Given this list of marker genes Casq1, Actn3, Agt, Prkag3, Trim63, Fbxo32, Dag1, Sgca, Selenon, Srl, Rps6kb1, Mtmr4, Ndufs4, Hdac4, Scn5a, Myog, Nol3 (nucleolar protein 3 (apoptosis repressor with CARD domain)), Dmd, here is a description of the gene set: Mouse Gene Set: GOBP_RESPONSE_TO_STIMULUS_INVOLVED_IN_REGULATION_OF_MUSCLE_ADAPTATION studied in species Mus musculus Any process that results in a change in state or activity of a cell or an organism (in terms of movement, secretion, enzyme production, gene expression, etc.) as a result of a stimulus. This occurs as part of the regulation of muscle adaptation.